The following is a description of a gene set: Human Gene Set: MIR1288_5P Genes predicted to be targets of miRBase v22 microRNA hsa-miR-1288-5p in miRDB v6.0 with MirTarget v4 prediction scores > 80 (high confidence targets). from publication Chen Y, Wang X (PMID 31504780) studied in species Homo sapiens, and this is the list of marker genes: FAM114A2, TAOK1, ZFAND6, CYP7B1, ZNF280B, RRAS2 (RAS related 2), COLEC10 (collectin subfamily member 10), CADPS, FMC1-LUC7L2, ZNF764, MEMO1, BRAT1, MAGOHB, RIMS2, TNPO1, KAT7, CCDC91, MOSPD2, NALCN, FGFBP2, LUC7L2 (LUC7 like 2, pre-mRNA splicing factor), GBP6, PABIR3, TRAPPC8, BEND6 (BEN domain containing 6), SPINK5, YWHAG, GULP1, ZBTB8A (NCBI Gene Id 730411), ERVMER34-1, PLCB1, CERK, XRN2, GPR63, ADD2, SNX12, MEFV, CTNND2, EIF5B, C6orf120, SNRNP48, ASB8, SMARCA2, CD99 (CD99 molecule (Xg blood group)), PPP1R3B, PATZ1, SPO11, UBE2V1, SPATS2L, HDAC6, SETD7, TENT5A, NOVA1, CDC26